The following is a description of a gene set: A nuclear receptor activity regulated by steroid binding and modulating the transcription of specific gene sets transcribed by RNA polymerase II. Human Gene Set: GOMF_NUCLEAR_STEROID_RECEPTOR_ACTIVITY species: Homo sapiens, and this is the list of marker genes: OR51E2, GPER1, NR4A3, NR2E1, VDR, PAQR7, ESRRG, NR3C2, ABHD2, RXRB, PPARD, PGRMC2, ESR1, AR, NR2C1, RXRG, NR3C1, PGR, ESRRA, NR1D1, PAQR8, ESR2, PDE3A, RXRA, PPARA, ESRRB, NR2E3